The following is a description of a gene set: Mouse Gene Set: GOBP_POSITIVE_REGULATION_OF_GLUTAMATE_RECEPTOR_SIGNALING_PATHWAY species: Mus musculus Any process that activates or increases the frequency, rate or extent of glutamate receptor signaling pathway., and this is the list of marker genes: Ephb2, Prnp, Nlgn3, Unc13a, Shank3, Necab2